Given this list of marker genes SYTL5, GSTA1, CYP2C18, VNN1, ST6GALNAC1, ADH1C, MAL, ENDOU, NMRAL2P, KRT24, CEL, SPRR2C, FMO3, C12orf54, RARRES1, PAX9, SOCS2, KRT4, CYP26A1, FGF13, GDA, FAM3B, WNT2B, ALDH1A1, IL1RN, UPK1B, ADH7, FMO2, ADGRF1, AKR1C1, TMPRSS11B, HLF (NCBI Gene Id 3131), ALOX15B, CP, KLK13, VTCN1, SCEL, SERPINB13, UGT1A10, CRNN, DUOX2 (NCBI Gene Id 82430), NTS, MUC20, FAM83C, MRAP2, TMEM45B, CDH26, CYP2E1, MFSD4A, RASSF9 (NCBI Gene Id 9182), LINC01133, SUSD4, SLURP1, PRSS27, AADAC, UGT1A8, TGM3, ALOX12 (NCBI Gene Id 239), SPINK7, KRT78, IGF2BP3, CLCA4, POF1B, GPR15LG, PADI3, TMPRSS11D, CES1, NTRK2, KRT31, NPR3, GBP6, A2ML1, CCDC190, CEACAM7, MUC4, SLURP2, MSLN, CEACAM5 (NCBI Gene Id 1048), EPHX3, TMPRSS2, IL36A, ALDH3A1, CXCL17, FBN2, SLC7A11, RPTN, CD177, TMPRSS11E, here is a description of the gene set: Human Gene Set: RICKMAN_HEAD_AND_NECK_CANCER_E Cluster e: genes identifying an intrinsic group in head and neck squamous cell carcinoma (HNSCC). Propensity for subsequent distant metastasis in head and neck squamous-cell carcinoma (HNSCC) was analysed using 186 primary tumours from patients initially treated by surgery that developed (M) or did not develop (NM) metastases as the first recurrent event. Transcriptome (Affymetrix HGU133_Plus2, QRT-PCR) and array-comparative genomic hybridization data were collected. Non-supervised hierarchical clustering based on Affymetrix data distinguished tumours differing in pathological differentiation, and identified associated functional changes. Propensity for metastasis was not associated with these subgroups. Using QRT-PCR data we identified a four-gene model (PSMD10, HSD17B12, FLOT2 and KRT17) that predicts M/NM status with 77% success in a separate 79-sample validation group of HNSCC samples. This prediction is independent of clinical criteria (age, lymph node status, stage, differentiation and localization). The most significantly altered transcripts in M versus NM were significantly associated to metastasis-related functions, including adhesion, mobility and cell survival. Several genomic modifications were significantly associated with M/NM status (most notably gains at 4q11-22 and Xq12-28; losses at 11q14-24 and 17q11 losses) and partly linked to transcription modifications. This work yields a basis for the development of prognostic molecular signatures, markers and therapeutic targets for HNSCC metastasis. studied in species Homo sapiens from publication Rickman DS, Millon R, De Reynies A, Thomas E, Wasylyk C, Muller D, Abecassis J, Wasylyk B (PMID 18679425)